The following is a description of a gene set: The directed movement of a phospholipid out of a cell or organelle. species: Mus musculus Mouse Gene Set: GOBP_PHOSPHOLIPID_EFFLUX, and this is the list of marker genes: Abca12, Apoc3, Apoa4, Apoa1, Apoa5, Spns1, Apoc2l, Abcc1, Apoc1, Apoe, Abca3, Abcg1, Abca1, Apoc2, Abca7, Apoa2